Given this list of marker genes Cdipt, Fitm1, Rasgrp1, Unc13b, Rasgrp4, Pltp, Fitm2, Unc13c, Unc13a, Trpc2, Dgat1, here is a description of the gene set: studied in species Mus musculus Mouse Gene Set: GOMF_DIACYLGLYCEROL_BINDING Binding to a diacylglycerol, a diester of glycerol and two fatty acids.